Given this list of marker genes NVL, TERT, MCRS1, CACNB4, GLUL, NMD3 (NCBI Gene Id 51068), PINX1, BYSL, POLR1A, NPM1, here is a description of the gene set: Any process that modulates the frequency, rate or extent of protein localization to nucleolus. species: Homo sapiens Human Gene Set: GOBP_REGULATION_OF_PROTEIN_LOCALIZATION_TO_NUCLEOLUS